Given this list of marker genes Polrmt, Polr1b, Polr2b, Polr2a, Polr3b, Polr1a, here is a description of the gene set: The synthesis of RNA from a DNA template by RNA polymerase IV, originating at a Pol IV-specific promoter. studied in species Mus musculus Mouse Gene Set: GOBP_TRANSCRIPTION_BY_RNA_POLYMERASE_IV